The following is a description of a gene set: Human Gene Set: GSE20366_TREG_VS_NAIVE_CD4_TCELL_HOMEOSTATIC_CONVERSION_UP species: Homo sapiens from publication Feuerer M, Hill JA, Kretschmer K, von Boehmer H, Mathis D, Benoist C (PMID 20231436) Regulatory T (Treg) cells that express the FoxP3 transcription factor are essential for lymphoid homeostasis and immune tolerance to self. Other non-immunological functions of Treg cells, such as controlling metabolic function in adipose tissue, are also emerging. Treg cells originate primarily in the thymus, but can also be elicited from conventional T cells by in vivo exposure to low-dose antigen or homeostatic expansion, or by activation in the presence of TGFβ in vitro. Treg cells are characterized by a distinct transcriptional signature controlled in part, but not solely, by FoxP3. For a better perspective on transcriptional control in Treg cells, we compared gene expression profiles of a broad panel of Treg cells from various origins or anatomical locations. Treg cells generated by different means form different sub-phenotypes identifiable by particular combinations of transcripts, none of which fully encompass the entire Treg signature. Molecules involved in Treg effector function, chemokine receptors, and the transcription factors that control them are differentially represented in these subphenotypes. Treg cells from the gut proved dissimilar to cells elicited by exposure to TGFβ, but instead they resembled a CD103+Klrg1+ subphenotype preferentially generated in response to lymphopenia. Genes up-regulated in comparison of Homeo Convert versus Homeo Foxp3- (see Table 1S in the paper for details)., and this is the list of marker genes: TMEM64, XBP1, NIBAN3, HMGCR, COL15A1, MLST8, TENT5A, PDLIM4, STX1A, MIF, PRDM10-DT, PPA1, TLE2, SAMHD1, CNTROB, TEC, PARD6G, IKZF4, NUCB2, H2AZ1, STON1, IFT80, FAF1, TBCA, CDC14B, IL4R, PATL2, MKLN1, EXOSC8, EPSTI1, CRIP1, MUC1, TP53I11, IL2RA, IGHM, GPR83, NHP2, PRNP, MAN1A1, SOCS2, NABP1, SYPL1, LCLAT1, KPNA2, TRIM59, XKR5, RRAGD, S100A6, ITGA6, TRIP13, SEC24A, PTGR1, IKZF2, N4BP2, HSPD1, NDRG1, ZBTB32, MYB, AGT, HEMK1, GRB7, RAPSN, NHSL2, PGPEP1L, RWDD1, PENK, SELL, TNFRSF4, TNFRSF18, RIMKLA, IMPDH2, ADSS2, RCSD1, KCNJ15, TREML1, SLC35D1, STIM2, SNHG11, FOXC1, HIF1A, E2F7, GZMB, KRAS, NINJ2, TNFRSF9, IL17RB, CEP57L1, RBM38, DUSP4, CLSPN, RANBP1, TM4SF5, ATP2B4, SCD, ADA, IL1RL1, MTHFD1L, FAM83D, IRAK1BP1, GBP4, F2RL3, ARL5A, SRSF2, CRIPTO, MELK, NXPE4, VAV2, PDCD1LG2, AGPAT4, SLC2A3, AQP8, DBNDD2, HBS1L (NCBI Gene Id 22991), TGFBR1, GM2A, IGKC, PHLPP1, ZBTB18, HIPK2 (NCBI Gene Id 653052), ENTPD1, PTP4A3, FAM81A, CUBN (NCBI Gene Id 8029), SRGN, HINT1, CCS, EXOC2, FOXP3, GALK1, PPM1J, SPMAP1, IL2RB, DDN, ATP2A2, TREML2, AK7, SLC30A2, FNTB, PTAFR, REXO2, ALG8, REEP5, NCOA3, LARP1, P4HA1, TUBE1, SESN1, BCL3, TPP2, RBBP7, RNF39, TP53BP2, HNRNPAB, LANCL2, GCAT, CALR, NPC1, RAB26, PIWIL2, RRAS2, SGO2, PLAGL1, CSRP2, CHCHD10, NIBAN1, PIK3R3, AVEN, ITIH5, KLC3, LSR, DNAAF5, AOPEP, DGAT1, TMPRSS4, DLGAP3, YWHAZ, IFT57, FAM72A, MEDAG, MIF4GD, TBXA2R, CYP2D6, ECM2, ARID4B, UBE2D2, ETF1, CNDP2 (NCBI Gene Id 55748), GBP7, LGALS7, NME1, LCA5, PDE2A, DAG1, NEB, CAPRIN1, DNAAF4, SHMT2, CASTOR1, BUB1B, ITGAE